Given this list of marker genes Trp63, Psme3, Ppara, Rps15, Rps20, Rpl37rt, Trp53, Trp73, Cdkn2a, Cdk5rap3, Bcl2l1, Rpl37, Rfwd3, Marchf7, here is a description of the gene set: Mouse Gene Set: GOMF_MDM2_MDM4_FAMILY_PROTEIN_BINDING studied in species Mus musculus Binding to a member of the MDM2/MDM4 protein family, comprising negative regulators of p53.